Given this list of marker genes FCN1, TNFSF13B, HK3, PPM1K, OAS3, ASCL2, EIF2AK2, UNC93B1, REC8, NMI, MT2A, ALDH3B1, FFAR2, TMEM123, IFI44, LAMP3 (lysosomal associated membrane protein 3), SCO2, ACOT7, CD300C, TAP1, IRF9, AIM2, BATF2, GZMB, SDF2L1, UBE2S, JUP, DPYSL2, CDKN1C, ANKRD22, SRBD1, GRN, PLAGL2, TRIM38 (tripartite motif containing 38), LGALS9, ABCA1, IFIT1, BST2, LHFPL2, SPATS2L, CAP1, IL1RN, CD36, RNH1, CCR1, TICAM1, RRAS, HLA-DRB4, FAM8A1, UBA7, SOCS1, KIAA0319L (NCBI Gene Id 79932), AP5B1, HMOX1, TMEM268, MAD2L1BP, CST3, SLC37A2, GIMAP8, NRROS, LILRB1, MX1, SLC27A3, MT1F (metallothionein 1F), FLVCR2, NAGA, HES4, OAS2, PRF1, GNLY (NCBI Gene Id 7843), ADA, ZC3HAV1, NAGK, TLR7, IFITM3, GBP2, HSH2D, LMO2 (LIM domain only 2), TDRD7, CD68, SAMD4A, CHMP5, RIGI, ASPRV1, IFITM1, NT5C (5', 3'-nucleotidase, cytosolic), PATL1, DRAP1, GALM, KCNMB1, PLSCR1, NPC2, GBP5 (guanylate binding protein 5), SMCO4, UBE2L6, SIL1, PML, CTSL, NEXN, LAG3, SP110, MX2, CCNB2, DYNLT1, CDC20, GORASP1, TTYH3, MYOF, TRIM22, ATF3, CSRNP1, LDLR, CAMK1, C1QA, IFI30, IFIH1 (interferon induced with helicase C domain 1), IFIT3 (interferon induced protein with tetratricopeptide repeats 3), OASL, TMEM51, CCL8, PLAC8, TNFAIP6, CX3CR1, HERC5, APOL3, LAP3, TUBG1, PHACTR2, HLA-A, RNF31, ZFYVE26, C1QB, ACTA2, CDCA7, KIR2DL3, SHFL, GNA15, RIPK3, SCIMP, CD74, OGFR, PSME2, PHF11, DHRS9, SIGLEC5, ADAP2, SRC, NUB1, APOBEC3A, SQOR, NUSAP1, SCARB2, SRM, ATF5, TRAFD1, FCER1G, IDH2, MOV10, EPSTI1, SEPTIN4, CYBB, TNS3, CDKN1A, RGS12, RTP4, ZBP1, PARP10, CENPM, CYSLTR1, SAMD9L, SAT1, TRIM5, NTNG2, TAGLN, GPBAR1, MARCO, PARP14, FBXO6, MS4A7, IFIT2, KYNU, GLMP, MYDGF, TCN2, ADAR, TNFSF10, DDX60, TRIM26, SLFN12, XAF1, NCOA7, ISG20, SUSD1, EPB41L3, RGL1, VAMP5, CSF1R, RHBDF2 (rhomboid 5 homolog 2), SLC2A6, CNDP2, BTN3A1, TYMP, SIDT2, PARP9, GCH1, TXNDC11, CD38, ADA2, ABI3, PSME1, ZNFX1, TOR1B, GADD45B, OSBPL5, EMILIN2, PIK3AP1, CXCL10, IFI35, MYD88, TTC21A, CUL1, RNF135, IFI6, STAT2, LY6E, WARS1, SORT1, STAB1, FRMD3, KIR2DL4, SP140, TTC38, CD86, ANKFY1, TIMM10, RTCB, LGALS3BP, CMPK2, MOB3C, IFI44L, RBCK1, DUSP5, PCK2, STAT1, CEACAM1, MICB, SLC3A2, ISG15, GBP4, TMEM62, IFI16, GNGT2 (NCBI Gene Id 2793), PARP12, HELZ2, TENT5A, MAFB, SERPING1, SNTB1, DHX58, TMEM140, OTOF, MCM4, IRF7, NAPA (NCBI Gene Id 8775), PRAM1, HERC6, NLRP3, GBP1 (NCBI Gene Id 2633), TAP2, CDCA5, CASP5, CD163, MARCKS, IFIT5, APOBEC3F, BLVRA, IDO1, PTGDS, RIN2, SERTAD1, ACOT9, NOD2, IL15, OAS1, RAB8A (NCBI Gene Id 4218), HAVCR2, TRIM21, C3AR1, MT1A, SHISA5, RSAD2, IFI27, here is a description of the gene set: from publication Gaucher D, Therrien R, Kettaf N, Angermann BR, Boucher G, Filali-Mouhim A, Moser JM, Mehta RS, Drake DR 3rd, Castro E, Akondy R, Rinfret A, Yassine-Diab B, Said EA, Chouikh Y, Cameron MJ, Clum R, Kelvin D, Somogyi R, Greller LD, Balderas RS, Wilkinson P, Pantaleo G, Tartaglia J, Haddad EK, Sékaly RP (PMID 19047440) Correlates of immune-mediated protection to most viral and cancer vaccines are still unknown. This impedes the development of novel vaccines to incurable diseases such as HIV and cancer. In this study, we have used functional genomics and polychromatic flow cytometry to define the signature of the immune response to the yellow fever (YF) vaccine 17D (YF17D) in a cohort of 40 volunteers followed for up to 1 yr after vaccination. We show that immunization with YF17D leads to an integrated immune response that includes several effector arms of innate immunity, including complement, the inflammasome, and interferons, as well as adaptive immunity as shown by an early T cell response followed by a brisk and variable B cell response. Development of these responses is preceded, as demonstrated in three independent vaccination trials and in a novel in vitro system of primary immune responses (modular immune in vitro construct system), by the coordinated up-regulation of transcripts for specific transcription factors, including STAT1, IRF7, and ETS2, which are upstream of the different effector arms of the immune response. These results clearly show that the immune response to a strong vaccine is preceded by coordinated induction of master transcription factors that lead to the development of a broad, polyfunctional, and persistent immune response that integrates all effector cells of the immune system. Human Gene Set: GAUCHER_PBMC_YF_VAX_STAMARIL_UNKNOWN_AGE_7DY_UP studied in species Homo sapiens Genes up-regulated in peripheral blood mononuclear cell 7d vs 0d in unknown after exposure to YF-Vax/Stamaril, time point 7D